Given this list of marker genes HAGH, MGRN1, TSG101, NFIA, SUMO1, COG2, ACVR1B, CSF1R, UPK3A (NCBI Gene Id 7380), CTNNB1, PRSS23, DBN1 (NCBI Gene Id 1627), EIF4EBP2, SNRPE, NDUFAB1, PHLDA2, KTN1, PLLP (NCBI Gene Id 51090), IMMT, NCOR2 (NCBI Gene Id 9612), SSTR3, PYROXD1 (NCBI Gene Id 79912), PFKL, MUC5B, HS2ST1, TNFRSF4, STK35, CALM2, UBL3, HSPB2, NDUFB7, SMARCA5, DIMT1, UPF1, GHR, PRODH, INSL4, HLX (NCBI Gene Id 3142), RBM34, TFDP2, REEP5, GRIA2, LINC00847, KRT83, GADD45G, DNAH17, SPATA31C2, RFNG, TRIM44, AUH, SLURP1, TSN, SNW1, SSRP1, ORC2, SET, PTPRO, FXYD1, GPR183, PEBP1, TRAIP, SMARCA4, EFR3B, POLR3C, PHF24, LOXL1, INSL3, FUT1 (fucosyltransferase 1 (H blood group)), NR5A2, HDAC6, FGF4, APOC3, NRDC, CLDN4 (claudin 4), CT62, ZNF20, PDLIM3, HTATIP2, SLC11A2, COX5A, PSMD7, AQP4, KCTD20, ING2, ORC1, MSL1, UVRAG, GRIN2A, AIF1, FOXJ1, GLS, TLE1 (NCBI Gene Id 7088), PTPRK, CD302, TSPYL5, S1PR4, GPD1, MINPP1, TTLL3, TAL1, ANXA3, NXPH4, FOXG1, TECPR2, PPIC, RAC3, ST3GAL4, GPR35, MAPKAPK5-AS1, NAGLU, MTMR6, ZNF157 (zinc finger protein 157), ZNF124, CEBPA, NIPAL3, TAF10, MAGEA4, DNPEP, TONSL, TOB2, COMT, SCN1B, TRPC2, TFAM, G3BP2 (G3BP stress granule assembly factor 2), PDCD10, G6PC1, COX7B (NCBI Gene Id 1349), PCSK5, TIAM1, HMGB2, SMURF2, CDKN1B, CREBL2, MDH2, AMELX, LILRP2, CRAT, TOP1, CELF2, TAF15, FOXN1, MTM1, ABCD3, TRIM3, CYC1, CRYAA, ZNF274, EXD2, PSMA7, AOC1, PFDN4, PPP1R16B, CELF3, APLP1, HDAC1 (NCBI Gene Id 3065), SCAND2P, SPRR1A, SRP9, PRKG2, CLASP1, ADRA2A, RNF126, AKAP4, AVPR2, CYP19A1, NIPSNAP1, SRPX, IL4, SRY, MEIS3P1, PGRMC1, ISL1, SOX4, SLC46A3 (NCBI Gene Id 283537), TBC1D2B, SCAP, SFTPC, EXPH5, MARCHF2, RBCK1, FLNA, PIN1, PTPN18, VARS1, CDK17, TMEM94, PARD6A, FEN1, CCN4, TPPP, FCGR2B, MAPRE1, FARP1, SV2C, ABL1, ADGRF5, RHOQ, CRISP1, PABPC1, here is a description of the gene set: Human Gene Set: GSE360_DC_VS_MAC_L_MAJOR_UP Monocyte-derived dendritic cells (DC) and macrophages (MΦ) generated in vitro from the same individual blood donors were exposed to five different pathogens, and gene expression profiles were assessed by microarray analysis. Responses to Mycobacterium tuberculosis and to phylogenetically distinct protozoan (Leishmania major, L. donovani, Toxoplasma gondii) and helminth (Brugia malayi) parasites were examined, each of which produces chronic infections in humans yet vary considerably in the nature of the immune responses they trigger. Genes up-regulated in comparison of dendritic cells exposed to L. major versus macrophages exposed to L. major. from publication Chaussabel D, Semnani RT, McDowell MA, Sacks D, Sher A, Nutman TB (PMID 12663451) species: Homo sapiens